Given this list of marker genes ALDH1A2, AGTR2, GDNF, HOXD11, SALL1, RET, GATA3, ROBO1, LHX1, FAT4, IFT25, SOX17, FOXC1, GFRA1, EYA1, SPRY1, CTNNB1, SIX2, SLIT2, GLI3, IFT27, PAX2, FOXC2, HOXC11, SOX11, ROBO2, HOXA11, BMP4, WT1, GREM1, HNF1B, here is a description of the gene set: GDNF/RET signaling axis Human Gene Set: WP_GDNFRET_SIGNALING_AXIS species: Homo sapiens